Given this list of marker genes TCERG1, NCAPD3, DDX39A, AFG3L2, GART, PLAAT3 (NCBI Gene Id 11145), BTG3, PRPS1, CCDC88C, MRPL11, RAD51, AK2, POLQ, PPAT, BRIX1, PSME3, NDUFA7, HCCS, ATP5MC1, PSMA3, SUV39H2, UBE2L3, HSD17B10, DIAPH1, KNTC1, TIPIN, EMC9, POLR2D, CFLAR, DONSON, BRCA1, CEACAM1 (CEA cell adhesion molecule 1), AVEN, FXN, CD200, SLC35F2, MAGOHB, EBNA1BP2, PSMB4, RUVBL2, MRPL28, RBBP4, MRPS31, MRM3, CSTF2, EXO1, SLCO4A1, EPRS1, SUPT16H, SNRPC, PPP1CA, KIF3A, CD320, CCT6A, NDUFAF4, NARS2, PON2, GRAMD1B, GSPT1, UBE2M, ZW10, PAICS, EIF5B, PPP1R16B, C1QBP, FAHD2A, ICMT, UBR7, DNAAF5, ARPC5L, CCT7, PSMD12, SLC25A32, ABCE1, OSBPL3, PLK1, DKC1, TTF1, GOT1, DGUOK, PSMB9, TFB2M, ARPP19, SSRP1, POLR3K, CAD (NCBI Gene Id 790), CWF19L1, C19orf53, PPIF, LANCL2, EZH2, CHORDC1, SP140, NCAPD2, TBPL1, TPD52, RIOX2, PTBP3, RWDD2B, RAD1, CCDC86, MRPL19 (NCBI Gene Id 9801), MICAL2, KDM1A, C12orf43, AP2B1, PPP1R14B, SLC39A14, TTK, MKI67, TEDC2, UBE2N, ORC3, DNAJC9, NIP7, MRPS16, RNASEH2A, FSD1, TRAIP, RFC4, TIMM13, PSMC3, DBF4 (NCBI Gene Id 10926), INPP1, SMS, H4C11, TMEM258, DUS4L, PRIM1, HJURP, CYB5B, NFATC2IP, NEIL3, NOL7, PUS7, NTHL1, PUDP, PFAS, NUP188, DDX10, SNRNP40, IDH3A, TRIP13 (NCBI Gene Id 9319), UCK2, NFYC, B3GNTL1 (NCBI Gene Id 359818), FASLG, BDH1, OGFOD1, RAD50, GTPBP4, SRRD, MAK16, UCHL3, NAA10, CENPS, PPID, AKIP1, RRP15, PPCDC, NEK2, ERH, NOP16, SEPHS1, MYBL2, PUM3, ILF2, ASNS, PHB1, OIP5, GEMIN6, TMA16, DNAJC2, POLE3 (DNA polymerase epsilon 3, accessory subunit), PXMP2, CENPQ, ELOVL6, PSD4 (NCBI Gene Id 23550), CDCA3, EMC6, ORC2, TIMM10, CDT1, TDP1, ABTB2, HEATR1, UTP11, RFC2, SLC16A1, NMI, FAM124B, EIF2B3, ERCC6L, SLBP, UBIAD1, COQ7, HSPA14, BCAR3, LRRC42, GMPS, here is a description of the gene set: species: Homo sapiens Genes up-regulated in comparison of CD25+ T cells treated with IL4 versus CD25- T cells treated with IL4 at day 5. from publication Prots I, Skapenko A, Lipsky PE, Schulze-Koops H (PMID 21347372) CD25+ regulatory T cells develop in the thymus (nTregs), but may also be generated in the periphery upon stimulation of naive CD4 T cells under appropriate conditions (iTregs). The mechanisms that regulate the generation of peripheral iTregs are largely unknown. We used microarrays to gain insights into the molecular program of extrathymic Treg development. Human Gene Set: GSE24634_TREG_VS_TCONV_POST_DAY5_IL4_CONVERSION_UP